Given this list of marker genes CLCA2, S1PR5, S1PR4, LMNTD2, CNST, NBR1, TNFRSF13B, EPC2, SMARCA2, MCFD2, LELP1, PI4KA, VMP1, SERPINF1, P2RY2, MOG, SHISA4, SRGAP2, HERPUD2, UNKL, ZKSCAN5, TAF1B, FKBP6 (FKBP prolyl isomerase family member 6 (inactive)), DACH2, BMP10, ATP6V0D1, STX5, OAZ2, SMPD5, ENO2, GOLGA1, CYSLTR2, BBS9, CHD7, HAND2, EXOC6, TGFBR2, PLCL1, GNB1, VIPAS39, DLGAP4, SLC15A2, PIP4P1, EPN3, MAP3K20 (mitogen-activated protein kinase kinase kinase 20), CTSE, NME8, RANBP10, TOR2A, TFAP2D, PBX2, MTMR3, GPR107, HSPA1A, HOXA11-AS, RABEP2, MB, CALU, DYDC2, GGT7, PMM1, MRPL9, COQ8A, CCNDBP1, LTO1, LRIG2, PHF8, LASP1, CLEC16A, CCDC183, CREBL2, RENBP, CPNE1, ITGB2, TMEM167B, IGFBP2, KLHL35, LIME1, ZFP82, ODF1, PLXNB2 (NCBI Gene Id 23654), EMB, ATG16L1, THAP1, ADAM19, SMO, SOX15, PTPRF, BARX1, C5orf34, SATL1, UBXN6, PNISR, ABLIM1, PLA2G4C, MYO9B, HSD11B2, MEIG1, NPC1, DBNDD2, UBA5 (ubiquitin like modifier activating enzyme 5), PLCD4 (NCBI Gene Id 84812), KLHL6, GOLGA3, UVRAG, MMP1, DCAF11, ALDOAP2, ITGB7, NEK9, NISCH, IBSP, CCDC185, TK2, COMMD8, ARL4C (ADP ribosylation factor like GTPase 4C), RFX5, HPS5, ING4, ITCH, JAK3, ZNF708, MSI1, VRK3, LUM, RANBP9, KDSR, DPY19L3, ORMDL3, VIM, TMEM176B, PSTPIP1, MOS (MOS proto-oncogene, serine/threonine kinase), GDF15, NFATC3, ENSA, ACAA1, RBM10, ATF7IP, SPHK1, RAD52, RELCH, ECM1, ERBIN, CCR5, GIT2, LINC00612, HDAC4, TCF25, STOML1, LMBRD1, C16orf54, ZNF341, HHEX, CFH, PAN2, TERF2IP, MYCL, BST1, TRMT9B, RNF145, SASH3, RHOF, CD2AP, EEPD1, SLC27A5, FILIP1L (filamin A interacting protein 1 like), TLX3, MATN1, DCBLD2, CHRDL2, CSNK1E, STK32B, BLOC1S6, ADAMTSL2, SLC30A4, SUGP1, ALDH1A3, TNIP2, RAPGEF6, PAK6, VPS39, PINK1, IL21 (NCBI Gene Id 59067), RAB3GAP2, ZNF692, SEC14L1, GLIPR1L2, RBM18, TPST2, LDHD, C19orf12, BSDC1, C1QTNF7, PTBP2, SPINK2, UPF2, FOXF2, NEB, SMAD5, here is a description of the gene set: studied in species Homo sapiens Human Gene Set: GSE4142_GC_BCELL_VS_MEMORY_BCELL_UP In order to better understand the factors that regulate B cell differentiation upon exposure to antigen, we compares global gene expression profiles from naive B cells with antigen-specific plasma, germinal center, and memory B cells after immunization with the T-dependent antigen, NP-CGG. The memory B cell-enriched transcripts were then compared with memory T cell-enriched and hematopoietic stem cell-enriched transcripts in order to generate a transcriptional profile of self-renewal within the hematopoietic system. Genes up-regulated in B lymphocytes: germinal center versus memory. from publication Luckey CJ, Bhattacharya D, Goldrath AW, Weissman IL, Benoist C, Mathis D (PMID 16492737)